The following is a description of a gene set: studied in species Mus musculus Mouse Gene Set: GOBP_PERIPHERAL_NERVOUS_SYSTEM_DEVELOPMENT The process whose specific outcome is the progression of the peripheral nervous system over time, from its formation to the mature structure. The peripheral nervous system is one of the two major divisions of the nervous system. Nerves in the PNS connect the central nervous system (CNS) with sensory organs, other organs, muscles, blood vessels and glands., and this is the list of marker genes: Pou4f1 (NCBI Gene Id 78006), Akt2, Itgb4, Pmp22, Cdk5, Ncmap, Raf1, Col6a1, Rela, Nefh, Lamb2, Ntf3, Dag1, Bag1, Lgi4, Slc25a46, Lama2, Agt, Pi4ka (phosphatidylinositol 4-kinase alpha), Sirt2, Vcam1, Nrg1, Map2k2, Ngf, Ndrg1, Nf1, Erbb2, Fa2h, Dmd, Ppp3r1, Pard3 (NCBI Gene Id 93742), Myoc, Adam22, Sox10, Grb2, Pou3f1, Ilk, Map2k1, Isl1, Pspn, Egr2, Ednrb, Artn, Erbb3, Sh3tc2, Sos1, Hoxd10, Nab2, Ntrk2, Cited2, Heyl, Prx, Mapk1, Adgrg6, Gpc1, Ascl1, Aldh3a2, Ski, Nhlh2, Akt1, Med12, Dicer1, Plec, Pou3f2, Hras, Hoxd9, Plxna4, Cldn1, Mapk3, Cntnap1, Pals1, Adgrb2, Sod1, Nab1, Osm, Hapln2, Gdnf, Slc5a3, Ren1, Arhgef10, Dhh, Hand2, Ntrk3, Tbce (NCBI Gene Id 77690), Egr3, Sox8, Onecut2